Given this list of marker genes Map2, Mecp2, Borcs5 (NCBI Gene Id 67774), Stk11, Trim46, here is a description of the gene set: species: Mus musculus Any process that activates or increases the frequency, rate or extent of vesicle transport along microtubule. Mouse Gene Set: GOBP_POSITIVE_REGULATION_OF_VESICLE_TRANSPORT_ALONG_MICROTUBULE